Given this list of marker genes TMEM41B, MRPL49, SOD2, PLD2, MAPKBP1, TTK, PDE4B, HEXIM1, PPP2R3A, TSPAN2, ANKRD33B, DSC2, IL32, SLC5A6, CD70, SLC22A23, RAB3IP, LAD1, ORMDL3, TNFRSF4, ZER1, ZBTB5, LMNB1, SUCO (SUN domain containing ossification factor), PRAME, GPR132, ZHX2, TPST1, CARINH, NEFH, PYM1, RAP2A, ZKSCAN5, CASZ1, PDRG1, S1PR1, BAIAP2L1, BCL9L, VCP, PTGIR, SEMA7A, CAMK1D, GNE, MSMO1 (NCBI Gene Id 6307), ECE1, CCDC127, KLF5, CGN, INSM1, MROCKI, TLCD3A, IRF1, IL15RA, SERPINB9, NIBAN1, DUSP5 (dual specificity phosphatase 5), PCNX3, PTGS2, FSCN1, SRSF12, SIAH1, TMEM41A, APOL1, LDLR (low density lipoprotein receptor), PTGR3, TMOD2, C5orf15, DENND4A, ZFTA, EBF1, MED21, SWAP70, CCM2, TARP, XCL1, SNX11, SPAG16, C15orf48, CHD2, KIFBP, LMNB2, TTC39A, C4orf46, IL23A, LXN, FLJ13224, GP9, SIAH2, EBI3, PIP5K1B, SRD5A1, MACROH2A2, TLCD1, RELB, NIM1K, NRG2, PDE4D, PRRG4, MAP3K1, NXT2, YPEL5, IL13RA1, HMGCR (NCBI Gene Id 3156), FOXP1, PVR, AOC1, MCF2, CSRNP1, H2AC25, VANGL1, OPTN, TRAF6, EDARADD (EDAR associated via death domain), TAMALIN, P2RY10, FSTL1, ENTHD1, CDK2, ALG2, UBE2Z, PIK3R3, PPCDC, NFATC2IP, CREB5, RABGAP1L (RAB GTPase activating protein 1 like), MELK, SNHG15, KIF2C, WHRN (whirlin), TNFAIP2, TNFAIP1, MPC2, PI4K2A, ZC3H4, MBOAT2, VAV2, CEP135, STC2, GRAMD1A, NBL1, SEMA4C, NEURL3, KLC2, C17orf58, TMSB15B, OTUD7B, CNN3, CSF2RA, PDCD1LG2, HMGN2P46, CFB, TRIP10, NFKBID, CMTR1, ISG20, CLCF1, H2AC13, CD200, SGPP2, ENOX1, TTYH2, PTPN1, TMEM131L, IL12B (interleukin 12B), HMGCS1, MED13, PPP2R1B, SUZ12, BCL2L1, PRPF40A, CEP68, MIA, SYNPO, IGSF8, ABTB2, ARHGEF17, GCH1, CDKN1A, TNFAIP6, DYNLRB1, LONRF1, TBCC, AURKA, LRCH3, PLAT, IL2RA, HPRT1, ORMDL2, H2AC8, MAP4K4, L3MBTL4, ZNF618, DNAI2, GADD45B, BMAL2, here is a description of the gene set: Human Gene Set: GSE45382_UNTREATED_VS_TGFB_TREATED_MACROPHAGES_DN studied in species Homo sapiens from publication Gu Z, Chhabra AY, Alard P, Warner DR, Kosiewicz MM (PMID 23643295) Genes down-regulated in macrophages: untreated versus TGFB2. F4/80+ macrophages treated with TGFb2 are potently tolerogenic. Our understanding of the molecular mechanisms mediating the development of these tolerogenic properties is incomplete. We used microarray analysis to identify molecules that are involved in the tolerogenic mechanisms in murine TGFb-treated macrophages.